Given this list of marker genes NOTCH4, HEY1, NOTCH1, HES1, JAG1, NFATC1, NOTCH3 (NCBI Gene Id 791), CALCR, RBPJ, TNFSF11, NOTCH2, DLL1, DLL4 (delta like canonical Notch ligand 4), JAG2, ACP1, DLL3, here is a description of the gene set: Human Gene Set: FUKUSHIMA_TNFSF11_TARGETS Notch signaling plays a key role in various cell differentiation processes including bone homeostasis. However, the specific involvement of Notch in regulating osteoclastogenesis is still controversial. In the present study, we show that RANKL induces expression of Jagged1 and Notch2 in bone marrow macrophages during osteoclast differentiation. Suppression of Notch signaling by a selective gamma-secretase inhibitor or Notch2 short hairpin RNA suppresses RANKL-induced osteoclastogenesis. In contrast, induction of Notch signaling by Jagged1 or by ectopic expression of intracellular Notch2 enhances NFATc1 promoter activity and expression and promotes osteoclastogenesis. Finally, we found that Notch2 and p65 interact in the nuclei of RANKL-stimulated cells and that both proteins are recruited to the NFATc1 promoter, driving its expression. Taken together, our results show a new molecular cross talk between Notch and NF-kappaB pathways that is relevant in osteoclastogenesis. studied in species Mus musculus Genes up-regulated in RAW 264.7 cells (macrophage) upon stimulation with TNFSF11. from publication Fukushima H, Nakao A, Okamoto F, Shin M, Kajiya H, Sakano S, Bigas A, Jimi E, Okabe K (PMID 18710934)